Given this list of marker genes ROBO1, NEFH, SMIM8, CTH, GTF2B, MGME1, CHCHD3, MORC2, CWC15, ARMCX3, WDR12, CLCN6, LUC7L2, SELENOM, TRA2B, IRF6 (interferon regulatory factor 6), RDH12, ST8SIA1, RIDA, SUDS3, ETFDH, EVI2B, TMPRSS13, ANKRD40, SIRT4, WDR37, DALRD3, ESYT3, BMP7, NFKB2, SNTB2, PA2G4, KLRD1, TUG1, ALDH2, TRUB1, GCN1, LRRC8A, ZFP1, CPM, TRAF1, ARL5B, RAC3, ZFP69, SELENOI, DGKI, OPRK1, NDRG3, KLHL6, FAM229B, LGALS1, EXOSC2, SMAP2, SLC30A2, KIN, NFKBID, PCMTD1, SC5D, VPS26A, PDE4B, CACNG5, ST3GAL6, RFC4, GAPDH, TMED3, RRAD, ADCY6, CCR6, AKAP1, EZH2, PAN2, ANK3, DFFA, CCDC89, ACY1, PLEKHA1, F13B, PLEKHH1, EPHB2, PAPOLG, TRHDE, SYTL2, EPS8L1, ADGRF1, CD226, ZKSCAN3, SPNS1 (NCBI Gene Id 83985), CHST10, ARMCX4, PWWP2A, ORC4, GRAP, AIMP2, PLOD2, ACTL6B, SNX5, SLC8A1, PATL2, KIT, MYOM2, PPIP5K1, FZD2, PTPDC1 (protein tyrosine phosphatase domain containing 1), TBCA, TNIP1, PPRC1, IFTAP, ZNF516, P3H1, CYP2S1, C2orf72, LCMT2, KRTAP4-7, COL6A3, RPAP2, ULK1, LZTFL1, PIM2, ICA1L, AGR3, GIT2, CATSPER3, SMARCAL1, TTLL4, IQCK, CPB1, CD8B, TRIM71, CD7, SH3YL1, TXNL4A (thioredoxin like 4A), ZPR1, CD70, RBM5, SRP9, SLC28A2, HAUS3, GPRASP2, TBX21, MCOLN3, RTKN2, WIPF3, COX18, GABRD, HTR1A, RHOJ, RSRC2, FAAH (NCBI Gene Id 2166), TMEM255A, MBLAC2 (NCBI Gene Id 153364), PSMD14, BRCA1, ELP4, ACOX2, RPL7, DNAJB6, EPSTI1, PMM1, TSEN2, PFKFB1, ZBTB25, FAM169A, PBX4 (NCBI Gene Id 80714), B3GNT3, USF1, CNOT6, GMFG, HLA-DOA, HOPX, MID1, RILPL1, ZFP37, TMEM154, LCP2, CSPG4, STX12, DUSP19, KEAP1, PTGFRN, APIP, MISP, VASN, POLR1C, MMEL1, HLA-B, DCTD, BANK1, SLC25A4, COMP, VSIG10, KLHL12, MTA3, GOPC (golgi associated PDZ and coiled-coil motif containing), FAM114A2, BBS12, QPCT, SMAD7, EHD3, APH1B, ECHDC2, here is a description of the gene set: Genes down-regulated in B cells: light versus dark zone. Human Gene Set: GSE23925_LIGHT_ZONE_VS_DARK_ZONE_BCELL_DN from publication Victora GD, Schwickert TA, Fooksman DR, Kamphorst AO, Meyer-Hermann M, Dustin ML, Nussenzweig MC (PMID 21074050) Microarrays of gene expression in mouse germinal center B cells photoactivated in the light zone or dark zone, and of naïve cells for comparison. We used microarray data to identify genes differentially expressed by B cells in the light and dark zones of the germinal center. studied in species Homo sapiens